Given this list of marker genes Sema4a, Sema3a, Sema7a, Sema3f, Taok2, Sema4d, Sema4c, Sema3c, Sema4g, Sema4f, Sema3d, Sema3b (NCBI Gene Id 20347), Pxn, Sema3g, Abl1, Vegfa, Sema4b, Sema3e, here is a description of the gene set: Binding to a member of the neuropilin family. Mouse Gene Set: GOMF_NEUROPILIN_BINDING studied in species Mus musculus